Given this list of marker genes CUL3, MSL2, MARCHF7, FBXL2, ITCH, UBE2W, TRIM56, RBX1, UBE3D, HUWE1, FANCM, RNF126, TRIM37, KLHL22, PDCD6, FANCL, UBE2N (ubiquitin conjugating enzyme E2 N), NEDD4, CUL1, ZNF598, STUB1, UBE2E3, UBE2E1, UBE2R2, NEDD4L, UBE2E2, ZC4H2, PEX12, KLHL12, MGRN1 (NCBI Gene Id 23295), NEURL1, RNF10, TOPORS, RAD18, BIRC2, UBE2O, UBE4B, OBI1, RNF152, WDR48, TRIM21, TRIM41, DTL, CBL, TRIM25, UBE2D3, PRKN, PEF1, SKP1, KBTBD8, UBE2T, RNF220, PEX2, UBB, here is a description of the gene set: Addition of a single ubiquitin group to a protein. Human Gene Set: GOBP_PROTEIN_MONOUBIQUITINATION species: Homo sapiens